The following is a description of a gene set: studied in species Homo sapiens Genes upregulated in subsets of cells of a given type within various tumors Human Gene Set: GAVISH_3CA_MALIGNANT_METAPROGRAM_METAPROGRAM_6_HYPOXIA In this study, an extensive analysis was conducted to define meta-programs (MPs) capturing intra-tumor heterogeneity across a spectrum of tumor types. The approach utilized non-negative matrix factorization (NMF) to analyze each cell type separately within individual tumor samples. This involved the analysis of malignant cells, macrophages, fibroblasts, endothelial cells, epithelial cells, T-cells, and B-cells. NMF was executed with varying parameter values (K=4, 5, 6, 7, 8, 9), thereby generating 39 programs for each cell type per sample. Each NMF program was summarized by the top genes based on NMF coefficients.\nRobust MPs were then delineated for each cell type using a set of stringent criteria, including recurrence within the same tumor, similarity to programs in other tumors, and non-redundancy within a tumor. Subsequently, these robust NMF programs were clustered (per cell type) based on Jaccard similarity, leading to the identification of MPs associated with each cell type.\nTo enhance the quality of the MPs, a refinement steps were undertaken, involving the removal of MPs suspected of reflecting low-quality data (with an overrepresentation of ribosomal proteins or mitochondrial-encoded genes), single-study inclusion, or similarity to miss-annotated cell types. from publication Gavish A, Tyler M, Greenwald AC, Hoefflin R, Simkin D, Tschernichovsky R, Galili Darnell N, Somech E, Barbolin C, Antman T, Kovarsky D, Barrett T, Gonzalez Castro LN, Halder D, Chanoch-Myers R, Laffy J, Mints M, Wider A, Tal R, Spitzer A, Hara T, Raitses-Gurevich M, Stossel C, Golan T, Tirosh A, Suvà ML, Puram SV, Tirosh I (PMID 37258682), and this is the list of marker genes: C4orf3, ERO1A, PLOD2, WSB1, AK4, TMEM45A, S100A10, SLC2A1, DNAJB9, AKAP12, FAM162A, ANKRD37, IGFBP5, EGLN3, LGALS3, BNIP3, SLC3A2, PFKP, GPI, MT2A, ANGPTL4, HK2, EPB41L4A-AS1, PFKFB3, PDK1, IGFBP3, NDRG1, BNIP3L, INSIG2, GBE1, LDHA, NRN1, ENO1 (NCBI Gene Id 81977), NDUFA4L2, CAV1, SLC16A3, ALDOA, ADM (NCBI Gene Id 133), CA9, CA12, DDIT4, VIM, P4HA1, DDIT3, MT1X, ENO2, ERRFI1, PGK1, VEGFA, HILPDA